Given this list of marker genes Sis, Gba1, Ganc, Lct, Gaa, Ganab, Mgam (NCBI Gene Id 676678), Pgghg, Agl, Gba2, Mgam2-ps (maltase-glucoamylase 2, pseudogene), Mogs, here is a description of the gene set: Catalysis of the hydrolysis of glucosyl compounds, substances containing a group derived from a cyclic form of glucose or a glucose derivative. Mouse Gene Set: GOMF_GLUCOSIDASE_ACTIVITY species: Mus musculus